The following is a description of a gene set: species: Homo sapiens expression profiles of FDC and BMDC are compared Genes up-regulated in dendritic cells: bone marrow-derived versus follicular. Human Gene Set: GSE4535_BM_DERIVED_DC_VS_FOLLICULAR_DC_UP from publication Nishikawa Y, Hikida M, Magari M, Kanayama N, Mori M, Kitamura H, Kurosaki T, Ohmori H (PMID 17015706), and this is the list of marker genes: DCXR, DOCK6, BMAL1, SLAMF1, ANKRD6, S100A4, SNAI2, TOX2, PBX3, CASP4, TRPM6, BTLA, UBE2N, GNG2 (G protein subunit gamma 2), NSD2, MALT1, SLC66A3, SNX2, ICAM4, TFE3, NRP1 (NCBI Gene Id 8829), POGLUT3, TXLNB, VAMP5, SH2D1A, SMTN, CYSLTR2, FCRL1, UAP1L1, LAMP2, POU2AF1, LNX2, S100A13, ST6GALNAC1, SMAD3, KCTD9, POLD4, HNRNPLL, SRGN, MRPS6, CD160, PLXNA3, AP1S1, ASAP1 (NCBI Gene Id 56237), COLCA1, DNAJC3, SNRNP25, CD38, MGAT5, IL12RB1, BMP7, PLAAT3, ANAPC10, MYO1C, TNP2, RAB19, VMP1, RAPH1, FAS, ORMDL2, GADD45B, ICA1, TTC39B, SNX25, TP53INP2, PDLIM7, SMIM7, FYN, DENND4C, TNFAIP8, HIGD1C, MPP1, H1-0, DDX24, GRAMD1B, ADAP1, MARCKSL1, SZRD1, TRIM37, CD200, PLEKHO2 (NCBI Gene Id 80301), SLC22A15, CCDC28B, BCL6, SLAMF6, LSM3, CHST2, CEBPG (NCBI Gene Id 1054), RNF149, RORA, TNFSF8, SAMSN1, ELP4, RAB3GAP2, ICA1L, TFRC, IL21, IL6ST, PHACTR2, CEP15, RASL11A, GRHL1 (NCBI Gene Id 29841), LBH (NCBI Gene Id 81606), CBR4, CD300LB, PTPN13, TMEM140, NFATC2, LRRC71, SMIM1, NFATC1 (nuclear factor of activated T cells 1), ZNF821, FUT8, CXCL10, SLC41A1, CALHM2, BCL3, PKP4, HDHD3, ANXA4, STK39, EVI2A, SH3GL3, ZNF518B, MDFIC (MyoD family inhibitor domain containing), PDE6D (phosphodiesterase 6D), SLC5A3, CASP1, GLOD4, ZDHHC2, TRIM36, TNFSF11, YBX3, ACOT7, S100A10, PTPN11, VAMP8, CEBPZOS, PRR13, TNC, SCRN3, SLC11A2, ARFGAP3, STX11, IRAG2, PPFIBP1 (NCBI Gene Id 8496), SH3RF1, PTPN22, ARHGAP26, PTGER2, FAM20A, ZMAT3, PGAM1, ABCB1, B3GNT2 (UDP-GlcNAc:betaGal beta-1,3-N-acetylglucosaminyltransferase 2), IKZF2, GCNT1, AREL1, PCOLCE2, KCNA3, PLSCR1, LRRC72, RAB43, IFI27L2, BAK1, GNG3, NDUFA13, TBC1D4, LUZP1, DPP4, MPP2, ADPRM, MGRN1 (NCBI Gene Id 23295), OAS1, REST, SNX14, ABTB3, PTPN1, CBFB, CFAP157, FBXO4, ITGB1, PKP3, LITAF, NDNF, PDCD1LG2, ATF6, ENDOD1, RNF157, HIVEP2, CLCN5, ELL2, TLE3, S100A11, TMEM86A, DYNLT3, CFAP126, MAPRE2, BATF, SEC14L1